The following is a description of a gene set: Effect of intestinal microbiome on anticoagulant response of vitamin K antagonists studied in species Homo sapiens Human Gene Set: WP_EFFECT_OF_INTESTINAL_MICROBIOME_ON_ANTICOAGULANT_RESPONSE_OF_VITAMIN_K_ANTAGONISTS, and this is the list of marker genes: PPARD, CYP2C9, NPC1L1, VDR, NR1I2, SCARB1, CD36, PPARA